The following is a description of a gene set: SLBP Dependent Processing of Replication-Dependent Histone Pre-mRNAs Mouse Gene Set: REACTOME_SLBP_DEPENDENT_PROCESSING_OF_REPLICATION_DEPENDENT_HISTONE_PRE_MRNAS studied in species Mus musculus, and this is the list of marker genes: Snrpb (small nuclear ribonucleoprotein B), Snrpf, Zfp473, Lsm10, Snrpd3, Ncbp1, Lsm11, Slbp, Snrpg, Ncbp2, Snrpe